The following is a description of a gene set: Human Gene Set: GOMF_MOLECULAR_FUNCTION_INHIBITOR_ACTIVITY species: Homo sapiens A molecular function regulator that inhibits or decreases the activity of its target via non-covalent binding that does not result in covalent modification to the target., and this is the list of marker genes: LAMP2, BIRC5, C3P1, PI15, WFDC2, SPINK8, MRLN, CSTB, DAXX, RTKN, ESR2, TMC7, NPM1, RPL37, PI16 (peptidase inhibitor 16), SLN, PPP1R14A, ANXA4, SOST, PPP1R16B, WFDC12, SNIP1, SERPING1, DNAJC3, OAZ2 (ornithine decarboxylase antizyme 2), COL6A3, CST6, SNCB, PPP1R12C, CST5, CABP1, MDFI, DFFA, MALAT1, COL28A1, SMR3A, SIRT1 (NCBI Gene Id 23411), PPP1R14C, MANSC4, HSP90B1, PPP4R4, TAF1, TCF23, AKT1, CST9, SPOP, SERPINA4, PPP1R27, WWP2, STX1A, NEDD4L, AHSG (NCBI Gene Id 780898), PPP1R12B, ID3, TFPI, SLURP2, CABIN1, NGF, WFIKKN2, ANXA3, UGT1A6, ACD, OAZ3, SSPOP, STYX, PAK1IP1, NEDD4, LY6S, TANK, SPOCK1, SPINK9 (serine peptidase inhibitor Kazal type 9), SERPINF1, WFDC5, PRKAR1B, URI1, NFIB, CARD17P, PDC, HEXIM1, PKIG, PROS1, LRRK2, PCYT1A, PPP1R10, GLMN, WFIKKN1, PDE6G, TIMP2, FKBP1A, CPAMD8, ITIH2, SLCO1B3-SLCO1B7, SERPINB7, PHACTR1, PABIR3, FNIP1, FKBP1B, PRKAG2, ERCC4, TNNI3, PKD1, TEN1, PCSK1N, U2AF2, EGLN1, BIRC6, BRAT1, PRKAR2A, GCHFR, DUSP22, SERPINB6, SPRED1 (sprouty related EVH1 domain containing 1), ITPR1, WFDC11, NHERF4 (NHERF family PDZ scaffold protein 4), CTNND1, LEF1, UBE3D, ITIH6 (inter-alpha-trypsin inhibitor heavy chain family member 6), SPINK4, SERPINA12 (serpin family A member 12), MCUB, IPO5, HMSD, CAV1, MLDHR, AGTR2, SIN3A, SERPINB1, GAPDH, PPP1R2, CCAR2, TUSC8, CST9LP1, SERPINA2, STYXL1, OPRPN, UGT1A7, SERPINB3, MAPK8IP1, LXN, NR0B2, FRAT1, HSPB1, SERPINB13, PPP1R1B (protein phosphatase 1 regulatory inhibitor subunit 1B), PLN, SERPINB9, CHMP3, CIB1, ATP5IF1 (NCBI Gene Id 93974), PRKCH, UCHL5, ITIH4, SH3BP5L, NFKBIA, HOTTIP, IL18BP, CARD16, CST7, DDIT3, FAF2, WFDC13 (WAP four-disulfide core domain 13), BEX2, PAPLN, CSN2, STOM, SPINT3, PPP1R26, OIP5-AS1, LY6H (lymphocyte antigen 6 family member H), PI3, SCG5, LMTK2, UGT1A1, IQGAP1, BIN1, SPINT1 (NCBI Gene Id 8610), CLEC12B, CRY2, NKX3-1, VTI1B, ARPP19, SERPINC1, KEAP1, WARS1, SIMC1, SCN3B (NCBI Gene Id 55800), BOD1, SERPIND1, YWHAG (NCBI Gene Id 96443), APOC2, APOC1, SERPINA7, GNAI1, LY6E, BEX4, TRIB2, PPP1R1C, STX8, USP14, PKD2, RNH1, AKT1S1, GNAZ, WFDC10A, CRB2 (NCBI Gene Id 286204), TIMP4, ID2, CDKN2A, GMFB, ITIH1, XIST, SERPINE3, PDE6H, PIF1, LCN1, ARHGAP5-AS1, IBTK, ITIH5, MACROH2A1, CST4, SERPINB5, TMBIM6, PREX1, ANOS1, SET, PKIB, PRPSAP1, WFDC3, STK39, TRIB3, HSPA1A, ATP2B1, CPEB2, CAMK2N2, SLCO1B3, CARD18, WFDC9, PTEN, NCOA2, USP10, CDKN2B, CDC42SE1, SLCO1B7, ADH7, TNK2, CDKN1C, KHDRBS1, KCNMB2, PRKAR1A, HEXIM2, SPINK1, CCL5, PPP1R37, CEP43, SH3RF2, WDTC1, CDKN2C, IGFBP2, PPP1R14D, PZP, PHPT1, RPL11, CST1, PPP1R14B, AMBP (alpha-1-microglobulin/bikunin precursor), SPRED2, LYPD1, TRIB1, UVSSA, BSN, DKK1, ANKRD36C, ANXA8, PCSK9, SPP2, PASD1, LRRC32, YWHAE, GSKIP, ELFN1, IQGAP2, SERPINB2, OAZ1, EZHIP, PPEF2, LAMP1, QARS1, C5 (NCBI Gene Id 727), UGT1A3, CIP2A, APBA3 (NCBI Gene Id 9546), MBIP, PABIR1 (NCBI Gene Id 116224), SPOCK2, ADGRV1, GSTM2, SRI, UGT1A4, CST9L, CAST, DKKL1, SERPINF2, FLCN, MCRS1, TMEFF1, A2ML1, SERPINI2, GBP2, SPINK2, TRAPPC2B, CHP1, UGT1A10, DUSP19, SLIT2, ANGPTL3, RACK1, ID4, DNAJB1 (DnaJ heat shock protein family (Hsp40) member B1), LINC-ROR, CAMK2N1, TIMP1, FURIN, TIPRL, THRSP (NCBI Gene Id 82916), PPP1R11, COL4A3, UGT1A9, BCL2, TSC1, CST3, WFDC6 (WAP four-disulfide core domain 6), PRKRIP1, SFN, SAG, SERPINA11, RPTOR, SLPI, PPP1R8, CALM2, CST8, SMCR8, CDKN2D, NRROS, ANO9, CASP3, PTP4A2, SERPINB12, ADRM1, DKK4, FNIP2, SERPINE1, PPP1R12A, ANKLE2, FRY, NFKBIL1, LPA, SCGB1A1, ANXA2, NOG, LYNX1, PRNP, TIMP3, LYPD6, KCNV1, FST, RPL5, SKI, PHACTR3, LIMK1, COL7A1, INCA1, KDM5A, GPC3, RGS2, ETFRF1, APP, KNG1, PPP1R17, CAV3, HSPBP1, SERPINA9, ANP32E, APOA2, HSP90AB1, RENBP, MICU1 (mitochondrial calcium uptake 1), LRP6, RPL23, DTX3L, ATAD3A, PPP1R35, SPINT4, CST11, RPS15, BEX1, PPP1R1A, ANKRD42, ELFN2, FETUB, PPP1R36, SERPINA6, PPP1R2P1, AGT, PEBP1, C4A, XIAP, C3, NAIP, PHACTR2, LTBP1 (latent transforming growth factor beta binding protein 1), RPS20, HSPA5, DUT, GMPPA, LRPAP1 (NCBI Gene Id 4043), HYAL2, PACSIN3, BST2, UMODL1, UGT1A8, SERPINA1, HAMP, CALM3, SH3BP5, EPPIN, PPP1R2C, SMAD5-AS1, PPP1R2B, ZNF451, SORL1, CFTR, TFPI2, INKA2, TPRN, SPINK14, DDX21, LYAR, CSTA, TESK1, SERPINA10, CLSTN3, ITPRIP, PDE6D, SLC30A1, PTN, ATP2B4, UCHL1, PXDN (peroxidasin), PLA2R1, SPINK13, ID1, KAT2B, DKK2, NCK1, TAF3, RHOH (NCBI Gene Id 399), SERPINH1, PPP1R9B, SERPINI1, A2M, TFDP3, BAG5, RARRES1, WFDC10B, GRM7, CDKN1B, ANXA2P2, NEAT1 (NCBI Gene Id 283131), WNK4, COMMD1, SPOCK3, SPINK7, NOLC1, MAPK7, NOTCH1, SERPINE2, SMO, SERPINB8, IL36RN, APLP2, R3HDML, SPINT2, MGAT5, CD109, LGALS3 (NCBI Gene Id 81625), IGSF1, SPRY2 (sprouty RTK signaling antagonist 2), GPS2, SMAD7, SERPINB4, ITIH3, CALM1, PREX2, GPS1, CST2, CTNNBIP1, CIT, REG1A, CDKN1A, TESC, IFIT1, SERPINB10, PPP5C, STX7, ANGPTL4, DEPTOR (NCBI Gene Id 64798), ARRB1, VAMP8, KCNK2, SOCS3, SMR3B, APOC3, IL1RN, PPME1, HTRA2, ANXA5, PARVA (parvin alpha), SMAD6, ANXA1, PKIA, GCKR, C1QBP, RSC1A1, OTUB1, RECK, DUS2, PARP9, KCNAB1, TMX1, LY6G6D, GSTP1, PTPRC, SNCA, DUSP3, WFDC8, INKA1 (inka box actin regulator 1), SERPINB11, NLRP7, RCAN1, PRPSAP2, TAOK3, PPP1R16A, BEX3, PRKAR2B, SERPINA3, C4B, UCN, LTF, PYDC1, SPINK5, CAMK2D, PURA, CRIM1, SPRY4, SIRPA, POT1, LILRB4, ENSA, PSMF1, DNM3OS, PABIR2, BIRC7, GBP5, RASA1, PTTG1, PINX1 (PIN2 (TERF1) interacting telomerase inhibitor 1), RPS7, CSTL1 (cystatin like 1), ELK1, THBS1, HES6, OXSR1, SCN1B, SERPINA5, SOCS1, HDAC6, DKK3, PPP2R5A, PARK7, PINLYP, GMFG, DYNLL1, ABCE1, HRG, TXNIP, FBXO5, WFDC1, SPINK6, KCNE4, YWHAB, MYOZ1